The following is a description of a gene set: Human Gene Set: KEGG_MEDICUS_REFERENCE_CXCR4_GNAI_PI3K_BAD_SIGNALING_PATHWAY studied in species Homo sapiens Pathway Definition from KEGG: CXCL12 -> CXCR4 -> GNAI -> PI3K -> PIP3 -> AKT -| BAD CXCR4-GNAI-PI3K-BAD signaling pathway. Pathway ID: N00430. Pathway type: Reference. Pathway class: nt06161 Human immunodeficiency virus 1 (HIV-1)., and this is the list of marker genes: GNAI2, GNAI3 (G protein subunit alpha i3), BAD, PIK3CD, AKT1, AKT3, CXCR4, PIK3CA, PIK3CB, AKT2, GNAI1, CXCL12